The following is a description of a gene set: species: Homo sapiens from publication Ngo TT, Peng T, Liang XJ, Akeju O, Pastorino S, Zhang W, Kotliarov Y, Zenklusen JC, Fine HA, Maric D, Wen PY, De Girolami U, Black PM, Wu WW, Shen RF, Jeffries NO, Kang DW, Park JK (PMID 17440165) Proteins with reduced expression in mulignant glioma cell line (A172) which bears loss of heterozygosity (LOH) in the 1p region. BACKGROUND: Malignant gliomas are generally resistant to all conventional therapies. Notable exceptions are anaplastic oligodendrogliomas with loss of heterozygosity on chromosome 1p (1p+/-). Patients with 1p+/- anaplastic oligodendroglioma frequently respond to procarbazine, 1-(2-chloroethyl)-3-cyclohexyl-l-nitrosourea, and vincristine. Because the underlying biologic basis for this clinical finding is unclear, we evaluated differentially expressed 1p-encoded proteins in 1p+/- and 1p+/+ malignant glioma cell lines and then examined whether their expression was associated with outcome of patients with anaplastic oligodendroglioma. METHODS: We used a comparative proteomic screen of A172 (1p+/-) and U251 (1p+/+) malignant glioma cell lines to identify differentially expressed 1p-encoded proteins, including stathmin, a microtubule-associated protein. 1p+/- and 1p+/+ anaplastic oligodendroglioma specimens from 24 patients were assessed for stathmin expression by immunohistochemistry. The relationship between stathmin expression and clinical outcome was assessed with Kaplan-Meier analyses. RNA inhibition and cDNA transfection experiments tested effects of stathmin under- and overexpression, respectively, on the in vitro and in vivo resistance of malignant glioma cells to treatment with nitrosourea. For in vivo resistance studies, 36 mice with intracranial and 16 mice with subcutaneous xenograft tumor implants were used (one tumor per mouse). Flow cytometry was used for cell cycle analysis. Immunoblotting was used to assess protein expression. All statistical tests were two-sided. RESULTS: Decreased stathmin expression in tumors was statistically significantly associated with loss of heterozygosity in 1p (P<.001) and increased recurrence-free survival (P<.001). The median recurrence-free survival times for patients with tumors expressing low, intermediate, or high stathmin levels were 45 months (95% confidence interval = 0 to 90 months), 17 months (95% CI = 10.6 to 23.4 months), and 6 months (95% CI = 1.7 to 10.3 months), respectively. Expression of stathmin was inversely associated with overall survival of nitrosourea-treated mice carrying xenograft tumors. Median survival of mice with stathmin+/- tumors was 95 days (95% CI = 68.7 to 121.3 days) and that of mice with stathmin+/+ tumors was 64 days (95% CI = 58.2 to 69.8 days) (difference = 31 days, 95% CI = 4.1 to 57.9 days; P<.001, log-rank test). Nitrosoureas induced mitotic arrest in malignant glioma cells, and this effect was greater in cells with decreased stathmin expression. CONCLUSIONS: Loss of heterozygosity for the stathmin gene may be associated with improved outcomes of patients with 1p+/- anaplastic oligodendroglioma tumors. Human Gene Set: NGO_MALIGNANT_GLIOMA_1P_LOH, and this is the list of marker genes: ENO1, ANXA2, HSPA5, P4HB, PARK7, TPM4, HNRNPK (heterogeneous nuclear ribonucleoprotein K), RPSA, ECHS1, SEPTIN2, VIM, STMN1, TPM3 (NCBI Gene Id 91191), GAPDH (glyceraldehyde-3-phosphate dehydrogenase), PGK1